The following is a description of a gene set: studied in species Homo sapiens Human Gene Set: GOBP_SMOOTH_MUSCLE_CELL_MATRIX_ADHESION The binding of a smooth muscle cell to the extracellular matrix via adhesion molecules., and this is the list of marker genes: EFEMP2, PLAU, APOD, SERPINE1, DDR1, VTN